Given this list of marker genes Pafah1b2, Pla2g10, Lcat, Pla2g7, Pafah1b3, Pafah2, Pla2g6, Aspg, here is a description of the gene set: species: Mus musculus Mouse Gene Set: GOMF_1_ALKYL_2_ACETYLGLYCEROPHOSPHOCHOLINE_ESTERASE_ACTIVITY Catalysis of the reaction: a 1-O-alkyl-2-acetyl-sn-glycero-3-phosphocholine + H2O = 1-O-alkyl-sn-glycero-3-phosphocholine + acetate + H+.